Given this list of marker genes Cited1, Ncoa3, Pcdh12, Ovol2, Itga4, Wnt7b, Birc6, Vcam1 (NCBI Gene Id 22329), Tmed2, Senp2, Fgfr2, Vash1, Synb (syncytin b), Cdx2, Lef1, Rbpj, Rtl1, St14, Mir127, Erf, Syna, Ccn1, Adm, Zfp36l1, Plg, Ggnbp2, Esx1, Grhl2, Cdx4, Spint2, Hs6st1, Ncoa6, Nsdhl, Vash2, Hes1, Bmp5, Ncoa1, Junb, Rspo3, Syde1, Il10, Llgl2, Spint1, Hey2, Plcd1, Map2k1, Gcm1, Grb2, Gjb5, Gab1, Fzd5, Akt1, Nfe2, Egln1, Mapk1, Hey1, Dnajb6, Plcd3, Wnt2, Fbxw8, Socs3, Bmp7, here is a description of the gene set: The process in which the labyrinthine layer of the placenta progresses, from its formation to its mature state. species: Mus musculus Mouse Gene Set: GOBP_LABYRINTHINE_LAYER_DEVELOPMENT